The following is a description of a gene set: from publication Amit I, Garber M, Chevrier N, Leite AP, Donner Y, Eisenhaure T, Guttman M, Grenier JK, Li W, Zuk O, Schubert LA, Birditt B, Shay T, Goren A, Zhang X, Smith Z, Deering R, McDonald RC, Cabili M, Bernstein BE, Rinn JL, Meissner A, Root DE, Hacohen N, Regev A (PMID 19729616) species: Homo sapiens Genes down-regulated in comparison of dendritic cells (DC) stimulated with poly(I:C) (TLR3 agonist) at 24 h versus DC cells stimulated with CpG DNA (TLR9 agonist) at 24 h. Human Gene Set: GSE17721_POLYIC_VS_CPG_24H_BMDC_DN mouse primary BMDCs were stimulated with tlr ligands and gene expression changes were profiled on Affymetrix arrays, and this is the list of marker genes: NEU2, EIF3E, ZC3H14, LYN, YBX3, GATB, PGAM1, SNIP1, RALGAPA1, RBM28, FABP7, PGRMC1, EEF1AKMT1, MRPL3, HNRNPK, PCNX1, CHST4, NXN, ZBTB8OS, VMP1, SLC4A7, TNFRSF21, GAL, MANF, YAF2, GPD2, CFLAR, XPOT, UEVLD, IMPA2, ABRACL, FIGNL1, NDUFAB1, PRKCH, TTC7B (NCBI Gene Id 145567), VPS28, C2orf76, OXSR1, TBXT, MEPCE, UBR1, SLC48A1 (NCBI Gene Id 55652), CKAP4, MAD2L1, CD48, BCR, HPGD, RAP1GDS1, SLC35C1, B3GALT2, PTPN14, TTI2, CDC16, NDC1, NDUFB6, TM9SF3, CHEK2, C21orf91, COL5A1, CASQ2, B4GALT1, PENK, RRM2B (ribonucleotide reductase regulatory TP53 inducible subunit M2B), AHCTF1, ARHGAP21, RNF19A, KIF13A, SPIC, PPP2CB, UBE2G2, CCT3, MMUT, RNF146, PANX1, RAC2, JAK2, FCER1G, LACTB, CHPF, APBB2, NTN3, UCHL1, WNT3, LIMS4, RNMT (RNA guanine-7 methyltransferase), PGC, FHIP1B, IMPACT, ANP32E, WWC1, CCDC71L, TAGLN2, GCLM, VAMP4, CHCHD4, CAV1, DIPK2A, BCCIP, SNTA1, MAPRE1 (NCBI Gene Id 22919), EIF3L, UBE2T, TMED4, NUCB1, MKI67, ZBTB44, POGLUT2, ACLY, DBT, STK3, MRPL41, ERO1A, MRPL52, HAS3, PSME3, ARHGAP23, NUP160, GPN1, NDRG1, COX8A, GCG, FERRY3, MECP2, B3GALNT2, RTCB, HERC2, ANTXR1, TARS1, ARCN1, AHSA1, CCL13, FOXK2, ABCE1, MAPKAPK2, SLC25A33, EIF1AX, LDAF1, TMEM147, AZIN1, VASP, MGA, FAM98A, LARP6, XRCC4, ATXN7L1, NPPC, OSTC, MMP2, COQ7, ENPP2 (NCBI Gene Id 5168), SIGLEC7, OR4E2, RRN3, APOC3, MFSD14A, CHRNA6, MRPL32, CYP51A1, NUTF2, SLC30A4, ERG28, CTC1, MLEC, CDC45, SRF, RXRA (NCBI Gene Id 6256), NOMO1, HSD17B4, SLC6A13 (NCBI Gene Id 6540), GSR, ADAM9, ALG14, SLC39A14, COX5A, GJA1, ANKRD13C, INTS1, UTP4, PITRM1, VPS26A, PIK3CG, NUS1 (NUS1 dehydrodolichyl diphosphate synthase subunit), MYBL2, CD44, PAX1, AGRN, ZNF598, OAZ2, PIWIL2, PTCD3, MAML1, FLNB, ULK2, TAF13, MLH3, RPA2, FKBPL, CD40, GTF2E2, CA13